Given this list of marker genes Abcd4, Ldlrap1, Lrp2, Mmaa, Lmbrd1, Mtr, Mmut, Cd320, Mmab, Mtrr, Mmadhc, Cblif, Mmachc, Abcc1, Tcn2, here is a description of the gene set: Cobalamin (Cbl, vitamin B12) transport and metabolism studied in species Mus musculus Mouse Gene Set: REACTOME_COBALAMIN_CBL_VITAMIN_B12_TRANSPORT_AND_METABOLISM